The following is a description of a gene set: Binding to a protein antigen. studied in species Homo sapiens Human Gene Set: GOMF_PROTEIN_ANTIGEN_BINDING, and this is the list of marker genes: SIRPA, LCK, ITGA4, EP400, PPP2R1A, PLG, KLRC1, KLRC2, KLRD1